The following is a description of a gene set: Genes up-regulated in monocyte-derived dendritic cells: LPS versus vehicle. from publication Fulcher JA, Hashimi ST, Levroney EL, Pang M, Gurney KB, Baum LG, Lee B (PMID 16785517) Human Gene Set: GSE4984_LPS_VS_VEHICLE_CTRL_TREATED_DC_UP Human monocyte derived dendritic cells matured via galectin-1 or LPS. studied in species Homo sapiens, and this is the list of marker genes: FBP1, TTC9, WDR24, ARFIP1, LINC02487, TBRG4, SELL, ATP8A2, BACE2, RIN3, GJB6, CFP, NLN, SLC19A1, MMAB, RCC2, HSD11B1, USP53, SLC25A37, TCF3, PITPNM2, SNORD46, MLST8, PRL, USP6, MIR106A, TYSND1, IRF4, MTRES1, UBALD2, FXYD7, MIR96, KIAA0319, CTSF, IPCEF1, PCED1A, NEK5, FITM2, GPR22, CDK4, DLL1, MEGF6, AMDHD2, FSTL3 (NCBI Gene Id 10272), LDLRAP1, TCTN3, ADAM18, RECQL5, SNORD53, GTF3A, ZBED3, PRKAB1, NXF3, STAT4, TRABD2A, RFX4, STK26, DHRS3, PIGP, CEACAM8, SNORD32B, OR10H3, ARHGEF26, EBAG9, GXYLT2, ZNF414, DNASE2B, DPPA3 (developmental pluripotency associated 3), TARS2, FBL, SNORD105, BTBD3, SMCO3, PFAS, SLC7A8 (solute carrier family 7 member 8), SPOCK3, PLAC8, PTGR2, CNTNAP5, TIMD4, MYLK2 (NCBI Gene Id 85366), HAVCR2, SETD6, PCSK6, HAVCR1, CYP4F8, KSR2, ACBD4, MRM1, IVD, MRPS24, GLRA2, SALL4, EFHC2 (EF-hand domain containing 2), SPTBN1, FBF1, CYP2J2, FCSK, DNAJC22, RANBP3, METTL3, ATP6V1E2, UBE3D, UBIAD1, ACTN1, KLHL3, MRTFA, ESYT2, NOG, AGTR1, AEBP1, RBFA, ERGIC1, SNORD14C, HBB, RNF157, GDPGP1, AGBL3 (NCBI Gene Id 79914), RRP12 (NCBI Gene Id 95039), VAX1, SNRK, AP1G2, BTNL8, LMLN, WRAP73, SEMA6D, KRT73, FCER1G, RNF113B, ALKAL1, PROCR, NTS, CD38, ENPP2, BAIAP2, SNORA5C, ZNF474, IGF2R, TMEM259, SDK2, GNPTAB, RPS25, LRRN1, AAMP, KRT72, PPFIBP2, SHISAL2A, PTPN6, MYB, ABCD2, TPST1, ZNF550, RCCD1 (RCC1 domain containing 1), WDFY2, EPB41L2 (NCBI Gene Id 2037), FAM117B, CD248, THOP1 (thimet oligopeptidase 1), BACH2 (BTB domain and CNC homolog 2), SYN2, RRP1, SLC25A42, POU2F2 (POU class 2 homeobox 2), ALDH3A2, PRKAR1B, SNORD116-25, NUCB2, UBXN11, SCARNA12, KCNQ1, TXK, C16orf74, RAPGEF6, C22orf15, MFSD13A, BZW2, RCAN3 (NCBI Gene Id 11123), KLF3-AS1, RFX2, TLE4, NUTF2, TBXA2R, MPP1, SNTG2, SPG7, CNN3, ELF3, USP19, IQCA1, MYO10, MIRLET7E, COQ8A, SH3RF3, NR1I3, TCF7, GAL3ST4, CHMP7